Given this list of marker genes Galnt16 (polypeptide N-acetylgalactosaminyltransferase 16), Tab3, Cacng2, Nmt2, Slx1b (NCBI Gene Id 75764), Bclaf1, Npas3, Ar, Slf2, Nucks1, Rnase4, 6030458C11Rik, Lpgat1, Hic2, Slc25a4, Tmem266, Pbx1, Hsbp1, Smndc1, Cacna1e, Trpc4, Zfp260, Gja3, Ntf5, Dclre1c, Dact1, Pou2f2, Tle4, Zfp131, Dek, Gbp7, Cntnap2, Fign, Zfp1009, Lmbr1, Acsl1, Tnks, Gfra1, Prdx6b, Tnrc6a, Vezf1, Nmral1, Car2, Tmed8 (transmembrane p24 trafficking protein 8), Tfcp2, Zfand3, Katnbl1 (NCBI Gene Id 98995), Stox2, Tnfrsf26, Tenm4, Serinc3, Snx7, Ube2ql1, Polr1g, Piwil2, Snap91, Zfp747l1, Fzd6, Unc79, Dnaja2, Eprs1, Nlrp4g, Lrfn5 (NCBI Gene Id 328106), Rab18, Col22a1, Sumo2, Tmem200c, Tmtc1, Eif5b, Kcnrg, Gm14288, Ankdd1b, Rasgef1a, Pcm1, Maco1, Ecpas (NCBI Gene Id 230249), Trpm3, Bbx, Kics2, Efhd1, Ano5, D630023F18Rik, Cntn1, Dpp9, Lamp3, Rere, Prdm6, Alppl2, Cdyl2, Eml5, Wdtc1, Oscp1, Nav1, Ttc39a (NCBI Gene Id 230603), Hcrtr2, Ssr1, Gns, Mfsd1 (NCBI Gene Id 66868), Mbnl1, Exoc3, Pals1, Itm2b, Col1a2 (collagen, type I, alpha 2), Rgs9, Clec2h, Tmem260, Deptor, Cetn3, Mtx2, Ccr4, Ikzf4, Thy1, Hycc2, Cdv3, Mettl21a, Lacc1, Rbmx, Thap4, Tmem230, Gabra5, Nde1 (NCBI Gene Id 67203), Kif21b, Dkc1, Nr2e1 (nuclear receptor subfamily 2, group E, member 1), Mtmr10, Olfm5, Sptbn1, Nefh, Tmem196, Sgip1, Greb1, Zfp950, Prkaa2, Hipk1 (NCBI Gene Id 68849), Egfl8, Dock4, Col12a1, Jag2, Grb2, Ddx42, Myom2, Pold3, Rrbp1, Tshz1, Capza1, Usp9x, Terf1, Akap13, Dedd, Cnfn, Dmrt3, Plppr4, Cwf19l2, Ube2b, Lin7a, Rab8a, Pno1, Tafa1, Kif1b, Srsf11, Haus2, Acer3, Gm2a, Fndc3b, Pi4k2a, Zscan18, Col2a1, Onecut2, Postn, Slc23a1, Ybey, Smc6, Hecw2, Zswim6, Tnpo3, Dynlt1c, Lig4, Zfhx3, Nsd2, Rapgef2, Lmna, Inhbb, Dmd, Ano4, Ascl4, Ltn1, Clec2d, Caln1, Slc10a3, Thoc3, Unc13c, Tnrc6b, Mylk (NCBI Gene Id 68242), Tmem39b, Mios, Ap1ar, Slc35e3, Stk3, Gga3, Ankrd66, Cttnbp2nl, Ski, Fam177a2, Eaf1, Adcyap1, Gatc, Castor2, Mdga2, Rufy2, Usp2, Ldlrad4, Gata1, Prtg, Rabgap1l, Xirp2, Lilrb4b, Ranbp9, Ankle2, Zfp704, Trim37, Arhgap35, Sptlc2, Hibadh, Ifnk, Phip, Cpne4, Ccdc14, Il6ra, Nutf2, Coq8a, Prickle1, Spred1, Ark2n, Nedd4l, Bcl9, Insig1, Cap2, Tead1, Xpo7, Jarid2, Nrf1, Prrx2, Eif1ad19, Tmcc1, Cdh12, Got2, Tmed7, Stag2, Slc31a1, Eef2kmt, Ankrd33b, Dop1a, C1rl, Armc2, Gad2, Lurap1l, Rac1, Hcn1, Ptp4a2, Pdlim5, Ntrk2, Diaph2, Robo2, Pbrm1, Sorl1, Plppr1, Rhoq, Ror1 (receptor tyrosine kinase-like orphan receptor 1), Gria3, Prss59, Grk3, Pou2f1, Ralbp1, S1pr3, Mthfd2, L2hgdh, Clec2i, B4galt6, Nfasc, Elovl7, Ptpn21 (NCBI Gene Id 24000), Arhgef9, Marchf8, Acer2, Mfsd9, Cdkn1a, Plxna4, Cdk12, Slc26a4, Fam177a, Nr2c2ap (nuclear receptor 2C2-associated protein), Pacrg, Bmp2k, Neurod1, Hoxb1, Rgs19, Frmd3, Ccnd2, Matr3, Mapk10, Pbx3, Gdi2 (GDP dissociation inhibitor 2), Huwe1, Smco1, Tfap2b, Tinagl1, Slc30a7, P2rx7, Nedd9, Faxc, Pax9, Pak3, Nkd1, Ppp2r1b, Itga1, Mex3c, Tgfbi, Il17rd, Wnt4, Zmym5, Fgd4, Acly, Ccng1, Isg20, Arhgef38, Ppp6r3, Lypla1, Hmx2, Hspb3, Alcam, Snx30, Gmeb1, Dynlt1b, Scmh1 (sex comb on midleg homolog 1), Ndufaf7, Pcdh7, Meox2, Flrt3, Sytl5, Camk1d, Slc25a48, Lrrc2, Zyg11b, Prps1l3, Slc16a1, Ghr, Tsr3, Lcorl, Zdhhc2, Zranb2, F2rl1, Scn3b, Lmo3, Septin2, Ms4a6c, Zrsr2, Pcsk2 (proprotein convertase subtilisin/kexin type 2), Papss2, Nt5c, Tra2a, Trim8, Pdgfra (NCBI Gene Id 231312), Ednrb, Arhgef12, Atp1b1, Fbxl17, Lhx6, Tbx3, Trp53inp1, Sema6d, Ttc9c, Cox7b2, Wipf3, Phactr3 (NCBI Gene Id 74189), Igf2, Raph1, Txnrd1, Cd164, Zbtb7a, 1600012H06Rik, Tent5c, Kcnma1, Nr2f6, Pcca, Ttll7, Ucp1, Ppp1r3d, Kdm4a, Smim13, Ifrd2, Psma2 (NCBI Gene Id 19166), Jazf1, Psmb11, Dcp1a, Tcf15, Chpt1, Ankrd12, Arid3a, Kansl1, Slc24a2, Acvr2b, Calb1, Fbxl3, Pmp22, Qrfp, Septin8, Synj2bp (NCBI Gene Id 28115), Tmem165, Dlgap1, Rin2, Zfp180, Txnl1 (thioredoxin-like 1), Dynll2, Hacd2 (3-hydroxyacyl-CoA dehydratase 2), 5730455P16Rik, Phf6, Def8, Idi2 (isopentenyl-diphosphate delta isomerase 2), Ppm1e, Phf21a (NCBI Gene Id 399586), Arrdc4 (arrestin domain containing 4), Mybl1, Med1, Pcnx1, Hyal1, Slc8a1, 4930596D02Rik, Gtf2b, Ttc32, Dynlt1f, Napb, Gtf3c2, Apod, Card6, Lsm10, Ntrk3, here is a description of the gene set: studied in species Mus musculus Mouse Gene Set: MIR_7065_3P from publication Chen Y, Wang X (PMID 31504780) Genes predicted to be targets of miRBase v22 microRNA mmu_miR_7065_3p in miRDB v6.0 with MirTarget v4 prediction scores > 80 (high confidence targets).